Given this list of marker genes DPY19L3, RNF6, UBL3, PRPSAP1, SLAMF7, MITF, ARFGAP3, COL24A1, DDHD2, HEPH, KLF11, PIAS2, GPD2, MYEF2, LRRC4, CTNNA3, CA3, CTPS1, TENM4, TIPARP, MTDH, DUSP4, LPA, ZCCHC17, AUTS2, TMEM182, RAB21, PUS7, DYRK4, ATP5F1C, SMCP, PAPOLB, INPP5A, ACSL3 (NCBI Gene Id 55484), ABCB5, ABCG1, GJB2, TTC39A, CDH13, SOX9, BCL11A, TRDN, FAM219B, POLR2M, XYLT1, CNR1, TBL1XR1 (TBL1X/Y related 1), SELENOT, MBNL1, GCOM1, NAA15, TYW1, here is a description of the gene set: Genes predicted to be targets of miRBase v22 microRNA hsa-miR-6876-3p in miRDB v6.0 with MirTarget v4 prediction scores > 80 (high confidence targets). from publication Chen Y, Wang X (PMID 31504780) species: Homo sapiens Human Gene Set: MIR6876_3P